The following is a description of a gene set: Any process that modulates the frequency, rate or extent of a cytoplasmic pattern recognition receptor signaling pathway. studied in species Mus musculus Mouse Gene Set: GOBP_REGULATION_OF_CYTOPLASMIC_PATTERN_RECOGNITION_RECEPTOR_SIGNALING_PATHWAY, and this is the list of marker genes: Plcg2, Trex1, Gbp5, Trim15, Irgm1, Pcbp2, Zdhhc12, Usp17le, Gbp2, Usp50, Dhx33, Hcfc2, Rnf170, Tlr4, Oasl1, Flot1, Aars2, Lyplal1, Trem2, Mavs, Nek7, Slc15a3, Dhx58, Usp15, Spsb3, Trim31, Rab7b, Ifi208, Casp4, Eif2ak2, Ifi203-ps, Peli3, Hspa1b, Tlr9, Cgas, Ifi213, Abhd17a, Zdhhc18, Nlrx1, Fbxl2, Cav1, Hspa8, Brcc3, Ifi206, F2rl1, Trim3, Zdhhc9, Zdhhc1, P2rx7, Ifi214, Stmp1, Gpatch3, Wdfy1, Cd36, Brcc3dc, Lats2, Smpdl3a, Ubqln1, Mapk8, Treml4 (NCBI Gene Id 75989), Atat1, Prkdc, Tirap, Ppp6c, Rsad2, Rtn4, Slc15a4, Aurkb, Trim11 (NCBI Gene Id 94091), Ankrd17, Src, Cd300ld3, Nlrc3, Cptp, Parp1, Ddx60, Myd88, Ogt, Tlr6, Tasl, Ifi207, Ppp2ca, Ptpn22, Lamp2 (lysosomal-associated membrane protein 2), Tkfc, Slc46a2, C1qbp, Zcchc3, Nploc4, Btk (NCBI Gene Id 215271), Irgm2, Erbin, Nop53, Hmgb1, Ddx3x, Igtp, Sec14l1, Kcnk13, Tspan6, Zdhhc5, Gm12250, Mndal, Ifi209, Zdhhc3, Tax1bp1, Akt1, Trim30a, Banf1, Map3k7, Peli1, Ufd1, Nagk, Pum2, Ifi203, Slc15a2, Mark4, Mefv, Prkd1, Slc19a1, D1Pas1, Ptprs, Znrf4, Gramd4, Riok3, Tab1, Ppt1, Sirt2, Zc3hav1, Lats1, Pum1, Tnfaip3, Csnk1a1, Tarbp2, Itch, Rnf125